Given this list of marker genes SMAD7, HFE, HJV, BMP6, HAMP, TMPRSS6, ID1, here is a description of the gene set: species: Homo sapiens Hfe effect on hepcidin production Human Gene Set: WP_HFE_EFFECT_ON_HEPCIDIN_PRODUCTION